Given this list of marker genes Fosl2, Six1, Mylk, Itga8, Npr2, Zfp950, Eng, Efemp2, Bmp4, Shh, Zfand5, Mir145a, Srf, Mir143, Nf1, Osr1, Smo, Tshz3, Tiparp, Schip1, Prox1, Sox9, Ptch1, Tfap2b, Stra6, Ihh, Pdgfrb, Dlg1, Tnn, Col3a1, Foxp1, Pkd2, Foxp2, here is a description of the gene set: The process whose specific outcome is the progression of smooth muscle over time, from its formation to the mature structure. studied in species Mus musculus Mouse Gene Set: GOBP_SMOOTH_MUSCLE_TISSUE_DEVELOPMENT